Given this list of marker genes MRAS, PPP1CA, BRAF, ARAF (NCBI Gene Id 369), PPP1CC, SHOC2, RAF1, PPP1CB, here is a description of the gene set: Human Gene Set: KEGG_MEDICUS_REFERENCE_REGULATION_OF_GF_RTK_RAS_ERK_SIGNALING_MRAS_SHOC2_PP1_HOLOPHOSPHATASE Regulation of GF-RTK-RAS-ERK signaling, MRAS-SHOC2-PP1 holophosphatase. Pathway ID: N01598. Pathway type: Reference. Pathway class: nt06526 MAPK signaling. species: Homo sapiens Pathway Definition from KEGG: (MRAS+SHOC2+PP1) -> RAF